The following is a description of a gene set: studied in species Homo sapiens Human Gene Set: REACTOME_REGULATION_OF_COMMISSURAL_AXON_PATHFINDING_BY_SLIT_AND_ROBO Regulation of commissural axon pathfinding by SLIT and ROBO, and this is the list of marker genes: SLIT2, ROBO3, DCC, SLIT1 (slit guidance ligand 1, NCBI Gene Id 6585), NELL2, SLIT3, NTN1, ROBO1, ROBO2, SRC